Given this list of marker genes GCSH, POLR1A, CFAP45, IFT27, CRELD1, DOHH (NCBI Gene Id 83475), here is a description of the gene set: Human Gene Set: HP_PARTIAL_ATRIOVENTRICULAR_CANAL_DEFECT A specific combination of heart defects including a primum atrial septal defect and cleft anterior mitral valve leaflet. There is not an inlet ventricular septal defect present. There are two valve annuluses and two valve orifices. Partial atrioventricular canal defect studied in species Homo sapiens